The following is a description of a gene set: Human Gene Set: GOCC_AXONEMAL_MICROTUBULE A microtubule in the axoneme of a eukaryotic cilium or flagellum; an axoneme contains nine modified doublet microtubules, which may or may not surround a pair of single microtubules. studied in species Homo sapiens, and this is the list of marker genes: SAXO4, DUSP21, TUBB4B, EFHC1, CFAP77, CFAP95, PIERCE2, CFAP68, TEKT5, EFHC2, ENKUR, CFAP53, CFAP52, RIBC2, RIBC1, CFAP144, CFAP210, PIERCE1, CFAP45, SPACA9, CIMIP2C, CIMIP2A, MNS1 (meiosis specific nuclear structural 1), SPMIP11, NME7, SAXO1, TEKT4, SPMIP10, ARFGEF2 (NCBI Gene Id 10564), CIMIP2B, SAXO2, TEKT2, SPMIP6, TEKTIP1, EFCAB6, PACRG, CFAP161, CFAP276, SPMIP8, CFAP20, CFAP206 (NCBI Gene Id 154313), SPMIP9, CFAP141 (NCBI Gene Id 388701), CFAP107, CEP162, CFAP126, EFHB, IFT70B, TUBA1A, CFAP90, TEKT1 (tektin 1), TEKTL1 (NCBI Gene Id 126402), SPAG8, ARL6, IFT70A, TEKT3